Given this list of marker genes CNTN2, RYK, PAFAH1B1, NGF, TRIM46, MAP6, NEFL, RGMA, ZFYVE27, PAK2, MACF1, GDI1, MAP3K13, SYNGAP1, EPHB3, DIP2B, THY1, KIAA0319, STK25, PSEN1, EFNB3, SEMA7A, MARK2, PAK3, TNFRSF12A, CDK5, PLXND1, DISC1 (NCBI Gene Id 80138, DISC1 scaffold protein), SHOX2, PLXNA3, RNF6, BRAF, TRAK1, ANAPC2, VEGFA (vascular endothelial growth factor A), BDNF, EPHB2, KIF13B, POU4F2, SMURF1, EPHA7, SEMA6D, TIAM2, AMIGO1, EFNA5, SKIL, CRABP2, MAP2K2, GOLGA4, SPART, RUFY3, TWF2, SEMA3F, UST, CDKL5, TRPC5, SEMA5A, IST1, NTRK3, RTN4, HDAC6, MAPT, ULK1, WNT3A, CHODL, SEMA4D, PLXNC1, DSCAM (DS cell adhesion molecule), PAK1, SHTN1, SRF, BMPR2, NTRK2, PTPRS, WNT3, MAG, ZEB2, ROBO2, MEGF8, LRP4, MCF2, NRDC, IFRD1, ADCY10, MAP1B, RET, BCL11A, CXCL12, DCC, SLITRK1, RND2, SLIT1, DAB1, SPP1, LPAR3, RTN4R, FSTL4, L1CAM, MT3, CDKL3, CHN1 (NCBI Gene Id 27011), ISLR2, KEL, METRN, POU3F2 (POU class 3 homeobox 2), MAP2K1, SEMA3G, PTEN, SIPA1L1, FGF13, EFNA1, ROBO1, PLXNB2, LRRC4C, ARHGAP35, NRP1, WNT5A, ADNP, SEMA6C, DRAXIN, PLXNB3, FN1, BRSK1 (NCBI Gene Id 84446), ARHGAP4, GSK3B, ULK2, SEMA4F, CDH1 (cadherin 1), LIMK1, TIAM1, CDH4, TNR, TRPV2, STK11, TRAK2, NTN1, PLXNB1, NIN, SLIT2, BRSK2, WNT7A, EPHA4, MAP2, XK, here is a description of the gene set: Human Gene Set: GOBP_REGULATION_OF_AXONOGENESIS studied in species Homo sapiens Any process that modulates the frequency, rate or extent of axonogenesis, the generation of an axon, the long process of a neuron.